The following is a description of a gene set: Binding to a class II major histocompatibility complex. Human Gene Set: GOMF_MHC_CLASS_II_PROTEIN_COMPLEX_BINDING studied in species Homo sapiens, and this is the list of marker genes: CD4, HLA-DRB5, YWHAE, HLA-DPA1, PKM, HSP90AA1, HLA-DMB (major histocompatibility complex, class II, DM beta), HLA-DRB1, HLA-DQB1, HSPA8, CD74, HLA-DQB2, HLA-DQA2, ATP1B1, HLA-DPB1, HSP90AB1, HLA-DOB, MS4A1, HLA-DMA, CD81, B2M, HLA-DRA, ANXA11, HLA-DQA1, HLA-DRB3, HLA-DRB4, HLA-DOA